Given this list of marker genes ADORA3, ADORA2A, P2RY12, ADORA2B, ADORA1, here is a description of the gene set: Combining with adenosine and transmitting the signal across the membrane by activating an associated G-protein; promotes the exchange of GDP for GTP on the alpha subunit of a heterotrimeric G-protein complex. Human Gene Set: GOMF_G_PROTEIN_COUPLED_ADENOSINE_RECEPTOR_ACTIVITY studied in species Homo sapiens